Given this list of marker genes USP8, SUMO1, SLC7A5P1 (NCBI Gene Id 81893), TMED10, RNF6, HARS2, RBM42, PSME1, EIF4E2, CD47, EEF1A2, PSMA2, GLOD4 (glyoxalase domain containing 4), YY1, DBI, ATP5F1C, SYPL1, BUD31, SIVA1, COX4I1 (NCBI Gene Id 1327), UBR5, TM9SF1, SKP1, TBCA, BBLN, SUPT4H1, DNAJA1, ATP6V1H, PSMC5, PSMB4, SPTLC1, PHF2, USP6, RAB5A, RPL36AL (NCBI Gene Id 93632), COX5A, HNRNPA3P1, MRPS11, FUBP1, LAMTOR5 (late endosomal/lysosomal adaptor, MAPK and MTOR activator 5), PSMC3, ATP5MF, NDUFB1, CNIH1, MBD4, CDK7, PSMD7, RNF114, STX16, ADAR, ANAPC13, UBXN4 (UBX domain protein 4), ELOB, ADNP (activity dependent neuroprotector homeobox), UBE4A, ETFA, CHMP1A, SEC11A, VTI1B, EIF5, RAB9A, UTP18, MAD2L1BP, COIL, PPP6C, PSMD9, CDIPT, COX17, PAF1, RBM4, NDUFA1, GABARAPL2, DPM1, LSM3, CFDP1, NEDD8, TLK2, SP2, ZNF410, PPP4C, PSMC1, CHMP2B, FUBP3, SNRPG, TMEM183A, RPP38, WASHC5, HSBP1, SAP18 (Sin3A associated protein 18), CNBP, PITRM1, SRP19 (signal recognition particle 19), PSMA3, RAE1, WIPI2, EEF1D, URM1, PSMC6, PDCD6, RAD23B, PPP1CA, POLR2G, NBN, VCP, here is a description of the gene set: Neighborhood of PPP6C protein phosphatase 6, catalytic subunit in the MORF expression compendium species: Homo sapiens Human Gene Set: MORF_PPP6C Neighborhood of PPP6C